The following is a description of a gene set: species: Mus musculus The progression of the pulmonary valve over time, from its formation to the mature structure. Mouse Gene Set: GOBP_PULMONARY_VALVE_DEVELOPMENT, and this is the list of marker genes: Notch2, Smad2, Bmp4, Tgfb2, Nos3, Slit2, Adamts19, Stra6, Robo1, Jag1, Robo2, Rbpj (recombination signal binding protein for immunoglobulin kappa J region), Nfatc1, Notch1, Tnfrsf1b (tumor necrosis factor receptor superfamily, member 1b), Tbx20, Hey1, Tnfrsf1a, Adamts5, Smad6, Heyl, Gja5, Bmpr2, Hey2